Given this list of marker genes TENM3, PCDH10, ARHGEF2, XPO1, PNMA1, here is a description of the gene set: Human Gene Set: MIR412_5P studied in species Homo sapiens Genes predicted to be targets of miRBase v22 microRNA hsa-miR-412-5p in miRDB v6.0 with MirTarget v4 prediction scores > 80 (high confidence targets). from publication Chen Y, Wang X (PMID 31504780)